The following is a description of a gene set: from publication Baek D, Villén J, Shin C, Camargo FD, Gygi SP, Bartel DP (PMID 18668037) species: Homo sapiens Genes up-regulated in 8 day cultures of bone marrow progenitors: wildtype versus MIR223 knockout. This array analysis is to study developmental time course of the regulation of target messages’ expression during culture of murine neutrophils versus miR-223 null neutrophils. Culture media was SILAC-IMDM for MS analysis. Human Gene Set: GSE12003_MIR223_KO_VS_WT_BM_PROGENITOR_8D_CULTURE_UP, and this is the list of marker genes: CPEB2, UTRN, ESYT2, ACAD10, HMGB3, FAM161A, WIPI1, ATP6AP1, TAX1BP3, PNRC2, MYOM2, C1GALT1, STX3, KLF7, FOLH1, CD163L1, SCARB2, CIRBP, EPHX4, COLEC11, LRRTM4, APLN, GABARAPL2, KLC1, DUSP1, TMEM134, FAM234A, RABAC1, CACNA1B, NLRC4 (NLR family CARD domain containing 4), C19orf38, PLCG1, TM4SF19, TMEM86A, LBH, HPCAL1, GUCY1B2, ARHGAP4, SIGLEC5, MESP2, MIR150, TTC3, SEPTIN1, HNRNPL, MNT (NCBI Gene Id 4335), HAUS4, NEK7, ZDHHC11, C1QC, MFGE8 (milk fat globule EGF and factor V/VIII domain containing), ASXL2, CTRB1, CRYGD, STX2, LIX1L, SYT9, PARP16, HAMP, TEDDM1, MS4A2, SFXN3, MMP3, TOM1L2, IL13RA1, EFCC1, TNFRSF14, VWA5A, NR3C1, CSTB, ZNF235, RNF148, KRTAP8-1, COX17, DYNC1I2, TENT5C, SGIP1, FHL3, CDH11, RENBP, ADRA2B, PGLYRP4, LGR4, KIF21B, IMPA2, NYX, PCDHB1, IL6ST, ELN, KAT6B, RERG, CSNK1G2, WDFY2, LPAR6, TMEM30A, RAB11FIP2, CD27, PTPRO, PURG, YPEL5, FMNL3, MIR345, PFN4, FBH1, RNASE11, CST9, BSDC1, CLEC12B, PHF23, KLC4, IER5L, MSRB2, KCNAB1, MAOB (NCBI Gene Id 4129), GNRHR, C16orf54, GPHA2, CORO1B, CTDSP2, CUZD1, RAB11FIP5, MIR221, SFXN4, SLC25A45, EHMT2, GIT2